Given this list of marker genes Inpp5j, Mtmr14, Inpp5e, Mtmr6, Inpp5k, Pip4p1, Inpp5d, Ptprq, Synj1, Mtmr7, Mtmr1, Inpp5b, Fig4 (FIG4 phosphoinositide 5-phosphatase), Synj2, Pip4p2, Mtmr4, Inpp4a, Mtmr2, Ptpmt1, Pten, Mtm1, Ocrl, Mtmr3, Inpp4b, Sacm1l, here is a description of the gene set: Mouse Gene Set: GOMF_PHOSPHATIDYLINOSITOL_BISPHOSPHATE_PHOSPHATASE_ACTIVITY species: Mus musculus Catalysis of the reaction: 1-phosphatidyl-1D-myo-inositol bisphosphate + H2O = phosphatidylinositol phosphate + phosphate.